The following is a description of a gene set: Abnormality of radial epiphyses Human Gene Set: HP_ABNORMALITY_OF_RADIAL_EPIPHYSES studied in species Homo sapiens, and this is the list of marker genes: BGN, IFIH1, COL9A3, SLC26A2, COL9A1, COL9A2